Given this list of marker genes MAOA, here is a description of the gene set: Reactome Pathway: Defective MAOA causes BRUNS Amine oxidase (flavin-containing) A (MAOA) catalyses the oxidative deamination of biogenic and dietary amines, the regulation of which is critical for mental state homeostasis. MAOA, located on the mitochondrial outer membrane and requiring FAD as cofactor, preferentially oxidises biogenic amines such as 5-hydroxytryptamine (5HT), dopamine, noradrenaline and adrenaline. Defects in MAOA can cause Brunner syndrome (BRUNS; MIM:300615), a form of X-linked non-dysmorphic mild mental retardation. Male patients are affected by mild mental retardation and exhibit abnormal behaviour, including impulsive aggression. species: Homo sapiens part of: Metabolic disorders of biological oxidation enzymes